Given this list of marker genes ALG3, CTR9, USP13, PLAGL2, DNAH3, ADCY2, CD28, ZNF202, SUPT4H1, MAPK1, H3C11, GRB2, MAGEA4, MT1B, INTS3, MTF2, IGHM, BBC3, CACNB4, CNKSR2, KIAA0753, GAK, IFNGR1, KATNA1 (NCBI Gene Id 11104), ARHGEF9, GALR2, PLA2G15, H4C9, SERPINB3, TRAF4, GHR, SMNDC1, KDM3B, TMF1, LRRN3 (NCBI Gene Id 92468), CPVL, TTC22, SNAP25, GRK3, SELENOW, TBL1X, COX10, APBB3, SNN, GYG1, PTPN7, GALNT1, EYA2, ADAM3A, NUTF2, CCDC85B, H2AC17, MARCKS, RNF13, DOC2A, NFATC2IP, BCL2A1, KLF6 (KLF transcription factor 6), MX2, CASP4, TCFL5, TUFM, PER2, KBTBD2, NAT9, CAPN7, PSMD7, GTF2A1, GIGYF2, CGRRF1, MAL, OARD1, PSMD13, IL10RA, TMEM97, CHST2, VPS13A, AJAP1, ATRX, TOM1, EPS8, PTPRM, ACADM, IFIT5, HERC3, CLIC5, COL21A1, PLXNC1 (NCBI Gene Id 121370), MAPRE3, TM7SF2, EXOC3, MMP10, UGCG, RCE1, LYST, SLC18A2, IFT70A, MSR1, F8, TRRAP, ANXA7, ABCC1, METTL3, ADO, DBN1, CAMKK2, P2RX4, CST7, PDE8A, TXNDC9, FANCI (NCBI Gene Id 751608), CDC42EP2, KAT6B, GPR50, PEX14, RAB32, CD40 (CD40 molecule), CHUK, ST8SIA1, ATOX1, RWDD2A, MOXD1, AK4, RAB4A, IPO5, SEC24A, ZNF423, FARSA, SLC35D1, GNG12, BRMS1, NRF1, PPP3CA, BAG2, NUP50, POLE, TBC1D1, SRGN, SHB, UPF1, BRD4, NFIL3, KITLG, MGRN1, RBM14, MSL3, UFD1, PIK3CD, AFP, ADAM21, BRD3 (bromodomain containing 3), ALDH9A1 (NCBI Gene Id 223), GPR18, ZNF428, SPA17, TAF11, LRRC32, PSMF1, PPARA, ZRSR2P1, KAT5, PEX3, UHRF2, ODF1, MPRIP, GOSR2, S1PR2, PTPN12, CPNE1, CDC25B, EPHX2, EBP, HAUS3, ATP10D, COL4A5, BMP2, GPR6, TADA2A, PPIA, HAL, PGD, ZNF92, ELMO1, HSPA6, ABCF1, CLPTM1, TWIST1, CEP43, NPEPPS, CNTN1, PROM1, KLHL18, CD5, LARP4B, NUDC, SPEN (spen family transcriptional repressor), SNCA, FAM161A, TULP2, here is a description of the gene set: Human Gene Set: GSE23321_CD8_STEM_CELL_MEMORY_VS_EFFECTOR_MEMORY_CD8_TCELL_UP An early-differentiated CD8+ memory T cell subset with stem cell-like properties (TSCM) can be identified within the naïve-like T cell population by the expression of CD95/Fas. Based on experiments including exon- and gene-level expression analysis, we provide evidence that this subset of antigen-specific cells represents an early precursor of conventional central (TCM) and effector (TEM) memory CD8+ T cells with enhanced self-renewal capacity and proliferative potential. We identified genes differentially expressed between major T cell subsets defined along with memory T cell commitment. Based on the analysis of these genes, CD95+ naïve T cells (TSCM) cluster closer to the CD8+ T memory compartment than to classical (CD95-) naïve T (TN) cells, and display an intermittent phenotype between classical TN and TCM cells in terms of all major T cell differentiation markers analyzed. studied in species Homo sapiens from publication Gattinoni L, Lugli E, Ji Y, Pos Z, Paulos CM, Quigley MF, Almeida JR, Gostick E, Yu Z, Carpenito C, Wang E, Douek DC, Price DA, June CH, Marincola FM, Roederer M, Restifo NP (PMID 21926977) Genes up-regulated in CD8 T cells: stem cell memory versus effector memory.